Given this list of marker genes Thrb, Fhip1b, Arid4a, Pcdha2, Gsk3b, Srrm3, Shisa7, Pcdha4, Mmp13, Apobec3, Pcdha5, Nr4a2, Pcdha6 (NCBI Gene Id 12937), Pcdhac1, Mpp7, Parp11, Pbx1, Trem4, Tspan18, Kcnj6, Scamp3, Rassf7, Arrb1, 4930558K02Rik (RIKEN cDNA 4930558K02 gene), Myod1, Sesn2, Zfp518a, Ms4a2, Hnrnpl, Map4k1, Pcdha11, Cramp1, Dpy19l2, Slc8a1, Fzd7, Pcdhac2, Nr1d2, Ube2ql1, Dlx3, Nectin2, Aqp4, Ptgdr, Trem5, Tubgcp4, Pcdha12, Ppme1, Ankrd63, Nampt, Pcdha7, Sri, Mrpl33, Pcdha3, Efna5, Reps2, Ppp1r1b, Ptp4a1, Pax8, Stim2, Irf9, Cpd, Sp1, Bbln, Pcdha9 (NCBI Gene Id 192161), Tyms, Taok2, Nptx1, Fbxw9, Pcdha1, Vegfb, Slc4a10, Tcte1, Pcdha10, here is a description of the gene set: Genes predicted to be targets of miRBase v22 microRNA mmu_miR_1941_5p in miRDB v6.0 with MirTarget v4 prediction scores > 80 (high confidence targets). from publication Chen Y, Wang X (PMID 31504780) studied in species Mus musculus Mouse Gene Set: MIR_1941_5P